Given this list of marker genes ACTB, ACTL6B, SMARCD1, ARID1A, DPF3, SMARCE1, SMARCA2, ACTL6A, SMARCD2, SMARCD3, SMARCB1, SMARCC1 (SWI/SNF related, matrix associated, actin dependent regulator of chromatin subfamily c member 1), SMARCC2, ARID1B, here is a description of the gene set: studied in species Homo sapiens A SWI/SNF-type complex that contains 8 to 14 proteins, including both conserved (core) and nonconserved components; contains the ATPase product of the Drosophila brm (brahma) or mammalian SMARCA2/BAF190B/BRM gene, or an ortholog thereof. Human Gene Set: GOCC_BRAHMA_COMPLEX